The following is a description of a gene set: studied in species Homo sapiens part of: Signaling by WNT in cancer Reactome Pathway: Signaling by CTNNB1 phospho-site mutants Mutations in exon 3 of the beta-catenin gene have been identified in a number of human cancers. These mutations generally affect serine and threonine residues (S33, S37, T41, S45) that are the sites of phosphorylation by CK1 and GSK3; phosphorylation of these residues is required for the ubiquitin-mediated degradation of beta-catenin. Hence mutation of these phospho-acceptor sites stabilizes beta-catenin, allowing it to accumulate, translocate to the nucleus and activate WNT signaling through association with LEF1/TCF DNA binding partners., and this is the list of marker genes: CTNNB1, APC, PPP2R5A, PPP2CA, PPP2R5C, PPP2R5E, GSK3B, CSNK1A1, AXIN1, PPP2CB, PPP2R5D, PPP2R1A, PPP2R5B, PPP2R1B, AMER1